Given this list of marker genes Tmc1, Tmc2, Slitrk6, Nr4a3, Zpld1, Pmp22, here is a description of the gene set: A reflex process in which a response to an angular or linear acceleration stimulus begins with an afferent nerve impulse from a receptor in the inner ear and ends with the compensatory action of eye muscles. Signaling never reaches a level of consciousness. Mouse Gene Set: GOBP_VESTIBULAR_REFLEX studied in species Mus musculus